The following is a description of a gene set: from publication Nikolsky Y, Sviridov E, Yao J, Dosymbekov D, Ustyansky V, Kaznacheev V, Dezso Z, Mulvey L, Macconaill LE, Winckler W, Serebryiskaya T, Nikolskaya T, Polyak K (PMID 19010930) Human Gene Set: NIKOLSKY_BREAST_CANCER_1Q32_AMPLICON A single cancer cell contains large numbers of genetic alterations that in combination create the malignant phenotype. However, whether amplified and mutated genes form functional and physical interaction networks that could explain the selection for cells with combined alterations is unknown. To investigate this issue, we characterized copy number alterations in 191 breast tumors using dense single nucleotide polymorphism arrays and identified genes with copy number gain organized into 30 amplicons. Amplicons were distributed unequally throughout the genome. Each amplicon had distinct enrichment pattern in pathways, networks, and molecular functions, but genes within individual amplicons did not form coherent functional units. Genes in amplicons included all major tumorigenic pathways and were highly enriched in breast cancer-causative genes. In contrast, genes with somatic mutations in breast cancer were distributed randomly over the genome, did not represent a functionally cohesive gene set, and were relatively less enriched in breast cancer marker genes. Mutated and gained genes did not show statistically significant overlap but were highly synergistic in populating key tumorigenic pathways including transforming growth factor beta, WNT, fibroblast growth factor, and PIP3 signaling. In general, mutated genes were more frequently upstream of gained genes in transcription regulation signaling than vice versa, suggesting that mutated genes are mainly regulators, whereas gained genes are mostly regulated. ESR1 was the major transcription factor regulating amplified but not mutated genes. Our results support the hypothesis that multiple genetic events, including copy number gains and somatic mutations, are necessary for establishing the malignant cell phenotype. species: Homo sapiens Genes within amplicon 1q32 identified in a copy number alterations study of 191 breast tumor samples., and this is the list of marker genes: IL10, IL20, SRGAP2, MAPKAPK2 (NCBI Gene Id 9261), IL24, IL19, IKBKE, FCAMR, PIGR, DYRK3, EIF2D, FCMR, RASSF5 (Ras association domain family member 5)